The following is a description of a gene set: species: Homo sapiens Human Gene Set: GOMF_DERMATAN_4_SULFOTRANSFERASE_ACTIVITY Catalysis of the reaction: n 3'-phosphoadenylyl sulfate + dermatan = n adenosine 3',5'-bisphosphate + dermatan 4'-sulfate + n H+., and this is the list of marker genes: CHST11, CHST13, CHST14, CHST8, CHST9